Given this list of marker genes GATA4, DVL1, SDHD, TBX20, EIF2AK4, ROR2, SELENON, MYH7, SLC34A2, TLL1, MYH6, ATRX, TTN, ATP13A3, CAPNS1, WNT5A, ACTC1, GATA6, CITED2, BMPR2, NKX2-5, here is a description of the gene set: species: Homo sapiens Anomalous physiology (function) of the right ventricle. Abnormal right ventricular function Human Gene Set: HP_ABNORMAL_RIGHT_VENTRICULAR_FUNCTION